Given this list of marker genes SCG2, IL16, MAP2K2, CADM1, ELK1, EGR1, GRB2, NPY, NRTN, GABRR1, ADGRL1, NTRK2, PRKCI, LDHA, SLC6A1 (solute carrier family 6 member 1), PCK1, DUSP6, EGR2, MAGED1, NPTX2, GAD1, CSF3, GIT1, GPR37L1, UBE2B, SYN1, VGF, ODC1 (NCBI Gene Id 4953), EGR4, MFGE8 (NCBI Gene Id 54740), MAPK1, here is a description of the gene set: Exercise regulated genes in hyppocampus. from publication Hunsberger JG, Newton SS, Bennett AH, Duman CH, Russell DS, Salton SR, Duman RS (PMID 18059283) Human Gene Set: HUNSBERGER_EXERCISE_REGULATED_GENES species: Rattus norvegicus Exercise has many health benefits, including antidepressant actions in depressed human subjects, but the mechanisms underlying these effects have not been elucidated. We used a custom microarray to identify a previously undescribed profile of exercise-regulated genes in the mouse hippocampus, a brain region implicated in mood and antidepressant response. Pathway analysis of the regulated genes shows that exercise upregulates a neurotrophic factor signaling cascade that has been implicated in the actions of antidepressants. One of the most highly regulated target genes of exercise and of the growth factor pathway is the gene encoding the VGF nerve growth factor, a peptide precursor previously shown to influence synaptic plasticity and metabolism. We show that administration of a synthetic VGF-derived peptide produces a robust antidepressant response in mice and, conversely, that mutation of VGF in mice produces the opposite effects. The results suggest a new role for VGF and identify VGF signaling as a potential therapeutic target for antidepressant drug development.